Given this list of marker genes Cyp1b1, Cyp2s1, Aloxe3, Cyp1a2 (cytochrome P450, family 1, subfamily a, polypeptide 2), Ptgis, Tbxas1 (NCBI Gene Id 21391), Cyp1a1, here is a description of the gene set: species: Mus musculus Mouse Gene Set: GOMF_HYDROPEROXY_ICOSATETRAENOATE_DEHYDRATASE_ACTIVITY A hydroperoxy icosatetraenoate = an oxoicosatetraenoate + H2O.